The following is a description of a gene set: species: Homo sapiens Reactome Pathway: Butyrophilin (BTN) family interactions Butyrophilins (BTNs) and butyrophilin like (BTNL) molecules are regulators of immune responses that belong to the immunoglobulin (Ig) superfamily of transmembrane proteins. They are structurally related to the B7 family of co-stimulatory molecules and have similar immunomodulatory functions. BTNs are implicated in T cell development, activation and inhibition, as well as in the modulation of the interactions of T cells with antigen presenting cells and epithelial cells. Certain BTNsare genetically associated with autoimmune and inflammatory diseases (Abeler Domer et al. 2014). <br>The human butyrophilin family includes seven members that are subdivided into three subfamilies: BTN1, BTN2 and BTN3. The BTN1 subfamily contains only the prototypic single copy BTN1A1 gene, whereas the BTN2 and BTN3 subfamilies each contain three genes BTN2A1, BTN2A2 and BTN2A3, and BTN3A1, BTN3A2 and BTN3A3, respectively (note that BTN2A3 is a pseudogene). BTN1A1 has a crucial function in the secretion of lipids into milk and collectively, BTN2 and BTN3 proteins are cell surface transmembrane glycoproteins, that act as regulators of immune responses. BTNL proteins share considerable homology to the BTN family members. The human genome contains four BTNL genes: BTNL2, 3, 8 and 9 (Abeler Domer et al. 2014). part of: Adaptive Immune System, and this is the list of marker genes: CD209, BTN2A1, XDH, BTN1A1, BTNL8 (butyrophilin like 8), BTN3A3, BTN3A2, PPL, BTN3A1, BTNL2, BTN2A2, BTNL9